Given this list of marker genes RPL13, TRPV4, CDC6, COL9A1, CHST3, COMP, DYM, ACAN, BPNT2, PEX5, SLC26A2, MATN3, COL11A1, SIK3, UFSP2, COL9A2, ADAMTSL2, COL2A1, TRAPPC2, KIF22, NMNAT1, NANS, TRIP11, COL9A3, RNU4ATAC, here is a description of the gene set: Human Gene Set: HP_IRREGULAR_EPIPHYSES species: Homo sapiens Irregular epiphyses An alteration of the normally smooth contour of the epiphysis leading to an irregular appearance.